The following is a description of a gene set: Human Gene Set: GOBP_REGULATION_OF_CIRCADIAN_RHYTHM Any process that modulates the frequency, rate or extent of a circadian rhythm. A circadian rhythm is a biological process in an organism that recurs with a regularity of approximately 24 hours. studied in species Homo sapiens, and this is the list of marker genes: PER1, RORC, RORB (RAR related orphan receptor B), MTOR (NCBI Gene Id 2476), PRKDC, FXR1, MAPK10, CSNK1D, KLF10, GHRH, SIK1, GNA11, TARDBP, FBXW7, PRKG1, PER2, ZFHX3, NONO, CRTC1, NPS, HNF4A, GHRL, USP9X, NMU, NKX2-1, MTNR1B, PER3, DRD4, ADCY1, PPARGC1A, SIN3A, OPN3, ATG7 (autophagy related 7), CCAR2, FBXW11, MAPK8, BTRC (NCBI Gene Id 8945), CRY2, NR2F6, ID2, CRY1, PML, KDM2A, PROX1, HNRNPD, CRH, ADORA1, PPARG, PARP1, NR1H3, FBXL3, PPARA, HCRTR2, CLOCK, PTGDS, PHLPP1, ROCK2, SIAH2, OPN4, DDB1, THRAP3, MAPK9, OPN5 (opsin 5), MAGED1, MAGEL2, NOCT, PPP1CA, FBXL21P, ADORA2A, TIMELESS, GSK3B, BMAL2, RBM4, USP2, SRRD, PRKCG, EZH2, PASD1, RBM4B, NR1D2, GNAQ, TP53, KAT5, RORA, PRKAA1, PDE6B, PPP1CB, SIRT6, SPSB4, PPP1CC, ADRB1, BHLHE40, CIPC, PRKAA2, MTA1, ATOH7, CDK1, NPY2R (NCBI Gene Id 4887), BMAL1, CSNK1E, PIWIL2, CSF2, TOP2A, DRD2, GHRHR, NR1D1 (NCBI Gene Id 9572), SFPQ, PSPC1, SOX14, CHRNB2, UBE3A, NLGN1, KCNA2, USP7, HDAC3